The following is a description of a gene set: Any process that activates or increases the frequency, rate or extent to which it enters into the host organism, where the two organisms are in a symbiotic interaction. studied in species Homo sapiens Human Gene Set: GOBP_POSITIVE_REGULATION_BY_SYMBIONT_OF_ENTRY_INTO_HOST, and this is the list of marker genes: FURIN, CD4, HMGB1, TMPRSS4, P4HB, HLA-DRB1, TRIM21, TMPRSS2, CD74, TRIM38, SMPD1, TRIM11 (NCBI Gene Id 81559), LGALS1, BSG, LGALS9 (galectin 9)